Given this list of marker genes STAT3, NCOA1, HRAS, REL, BCL2L1, RAC1, LEP, PRKAA1, JAK1 (Janus kinase 1), PLCG1, RHOA, ACACA, SOS1, MAPK8, ACACB, ELK1, SH2B1, FYN, PLCG2, PRKAA2, PIK3R2, KHDRBS1, EIF4EBP1, MAPK3, IKBKG (inhibitor of nuclear factor kappa B kinase regulatory subunit gamma), MTOR (NCBI Gene Id 2476), STAT5B, BAD, JAK2, RPS6KA1, SOCS7, GSK3A, PTPN1, IL1RN, RPS6KB1, SOCS3, SHC1, MAPK14, CREB1, MAP2K2, SRC, ESR1, RELA, IKBKB, BAX, CHUK (component of inhibitor of nuclear factor kappa B kinase complex), PTPN11, IL1B, RPS6, PTK2, CDC42, NOS3 (nitric oxide synthase 3), MAP2K1, PDE3B, GSK3B, FOXO1, NFKB1, CCND1, RAF1, ROCK1, MAPK1, ROCK2, ERBB2, CFL2, IRS1, LEPR, CISH, SOCS2, STAT1, PIK3R1, SP1, KPNA4, AKT1, PTEN, GRB2, EIF4E, here is a description of the gene set: Leptin signaling studied in species Homo sapiens Human Gene Set: WP_LEPTIN_SIGNALING